The following is a description of a gene set: species: Mus musculus Mouse Gene Set: GOMF_PRENYL_DIPHOSPHATE_SYNTHASE_ACTIVITY Catalysis of chain elongation of prenyl diphosphate substrates via one or more condensation reactions with isopentenyl diphosphate to generate linear polymers with defined chain lengths., and this is the list of marker genes: Fdps, Fntb, Pdss2, Dhdds, Cox10, Nus1, Pdss1 (prenyl (solanesyl) diphosphate synthase, subunit 1), Ggps1